Given this list of marker genes Ccne1, Cdkn1b, Ccnd1, Cdk4, Cdk2, Ptk6 (NCBI Gene Id 21880), here is a description of the gene set: PTK6 Regulates Cell Cycle studied in species Mus musculus Mouse Gene Set: REACTOME_PTK6_REGULATES_CELL_CYCLE